Given this list of marker genes Enpep, Osbp2, Foxf1, Ak7, Tmtc1, Tspan8, Unc93a, Clcn2, Spsb2, Dgkg, Rarres1, Exoc2, Psg25, Ttk, Rab5if, Enpp1, Aak1, Dapp1, Acaa2, Cast, Kctd1, Per2 (period circadian clock 2), Reep6, Robo2, Plppr5, Traf3, Pipox, Pfn2, Scn3a, Gabrp, Agtrap, Cmtm2a, Ppip5k2, Tmem114 (transmembrane protein 114), Suv39h2, Retreg1, Tada2b, Itga4, Bcs1l, Zfp105, Vbp1, Sh3gl2, Rftn2, Mtus2, Hnrnpul2, Lat2, 3830403N18Rik, Cstdc2, Nkd2, Hyal4, Smoc1, Atp5f1d, Mfap1a, Ctbs, Cpsf4, Dnmt3a, Uchl3, Sacs, Dis3l, Amer1, Acat3, Fam222b, Pigv, Iqcf3, Npas1, Tmem184a, Palld, Llgl2, Dennd5a, Abce1, Brdt, Tada2a, Marchf6, Adam12, Ermardl2, Mdm1, Spata21, Ywhaz, Hif1a, Trmt2a, Iars1, Fam107a, Rab3c (RAB3C, member RAS oncogene family), Gucy1a2, Rab9b, Snca, Samt4, here is a description of the gene set: Mouse Gene Set: MIR_6933_3P species: Mus musculus from publication Chen Y, Wang X (PMID 31504780) Genes predicted to be targets of miRBase v22 microRNA mmu_miR_6933_3p in miRDB v6.0 with MirTarget v4 prediction scores > 80 (high confidence targets).